Given this list of marker genes Proc, Bglap2, F10, F2, Proz, Ggcx, F7, F9, Pros1, here is a description of the gene set: Mouse Gene Set: REACTOME_GAMMA_CARBOXYLATION_OF_PROTEIN_PRECURSORS Gamma-carboxylation of protein precursors species: Mus musculus